Given this list of marker genes Polr1e, Ercc2, Taf1d, Polr1c, Polr2e, Polr2f, Polr1g, Ercc3, Polr2l, Ccnh, Gtf2h2, Gtf2h4, Tbp (NCBI Gene Id 21374), Polr2k, Polr1h, here is a description of the gene set: This event has been computationally inferred from an event that has been demonstrated in another species.<p>The inference is based on the homology mapping from PANTHER. Briefly, reactions for which all involved PhysicalEntities (in input, output and catalyst) have a mapped orthologue/paralogue (for complexes at least 75% of components must have a mapping) are inferred to the other species. species: Mus musculus part of: RNA Polymerase I Transcription electronically inferred by orthology from the curated human pathway Reactome Pathway: RNA Polymerase I Transcription Termination